The following is a description of a gene set: species: Homo sapiens Genes down-regulated in poorly differentiated thyroid carcinoma (PDTC) compared to normal thyroid tissue. Information on gene alterations associated to poorly differentiated (PDTC) and anaplastic thyroid carcinomas (ATC) is scarce. Using human cancer cell lines as a tool for gene discovery, we performed a cytogenetic and oligo-array analysis in five new cell lines derived from two PDTC and three ATC. In PDTC we evidenced, as important, the involvement of the MAPK/ERK kinase pathway, and downregulation of a group of suppressor genes that include E-cadherin. In ATC, downregulation of a specific group of oncosuppressor genes was also observed. Our ATC cell lines presented chromosomal markers of gene amplification, and we were able to identify for the first time the nature of the involved amplicon target genes. We found that the main molecular differences between the two cell line types were related to signal transduction pathways, cell adhesion and motility process. TaqMan experiments performed for five amplicon target genes and for two genes, which allowed a clear distinction between ATC and PDTC: CDH13 and PLAU corroborated array results, not only in the cell lines, but also in an additional set of primary 14 PDTC and three ATC. We suggest that our findings may represent new tools for the development of more effective therapies to the hitherto untreatable ATC. Human Gene Set: RODRIGUES_THYROID_CARCINOMA_POORLY_DIFFERENTIATED_DN from publication Rodrigues RF, Roque L, Krug T, Leite V (PMID 17406368), and this is the list of marker genes: ENOSF1, C9orf85, PPP1R21, SCARB2, HIVEP2 (NCBI Gene Id 3097, HIVEP zinc finger 2), DICER1, LRRC37A2, KSR1, CTSB, TBC1D32, JUN (NCBI Gene Id 3725), TNFRSF11A, HLA-DPA1, MAP3K1, C3orf52, TMTC1, VPS51, CACNA2D1, NFKBIA, GTF2H3, HES1, TTC7A, CTNND1, SLC41A1, RNF170, PLEKHH1, CD24P2, HBB, CD74, ACAA1, PRTG, UNC45A, RAB40B, RNASET2, TULP4 (TUB like protein 4), SLC25A3, SSBP2, PNISR, NEAT1, MGC16275, RILPL2, ABLIM1 (NCBI Gene Id 3983), CSNK2A1, COL3A1, CACHD1, BOC, ALDH3A2, SNTB1, MTMR10, IKZF2, SOBP, CDK13, FMNL3, MACROD1, APBB2, ZNF160, ACACB, METAP2, ANAPC5, CTSK, NOPCHAP1, ATF7IP, RFX1, MAN2C1, CD44, H3-3B, HLA-DRB1, NFIC, PRR4, ZNF573, CES2, FBXO25, NAMPT, MLXIP, HSD17B7, RPS6KA5, PLIN3, MBNL1, TCF4, PTPRB, RRBP1, TUSC2, SNAP23, C2orf68, PPP3CB, LNX1, XPO7, ACTA2, FZD5, SPRED1, CRIPT, ALDH5A1, YPEL1, CXorf38, ERAP1, DEDD2, MALAT1, WDR7, EPB41L5, RASSF4, SNRK, CIRBP, ATP1A1, HHEX, MRPL30, SBSPON, ELL2, TMED4 (transmembrane p24 trafficking protein 4), RGS5, MT1G, TSPAN31, GNAS, ZNF264, FBXO34, OFD1, TOX4, SNX1, SLC41A3, ERO1B, EPM2AIP1, ZBTB4, AKT3, PCBP2, LIMD1, MCCC2, CDON, MAP3K5, GRAMD2B, AGTR1, TSPAN6, AMY1A, GATM, ARID2, SLC4A4, RBPMS, NT5C3B, ITGAV, MAGI2, AKR1C1, WWOX, UVSSA, ZBTB18, NEDD9, UST, STMN3, RFFL, MAN2B2, ZNF75A, HAUS2, CLIP1, LATS1, DNASE1L1, FAM111A-DT, PROM2, SUGT1P3, TPST2, PRICKLE2, BBIP1, ECHDC2, RBL2, DMD, KLHDC1, ZMYM5, ACOX1, ELF2, SH3YL1, MYLK, MED13L, CCDC152, ARL4D, LTBP3, H1-10, KBTBD7, CXCL12, CITED2, DYNLL2, ATXN1-AS1, SLC45A4 (solute carrier family 45 member 4), SLC12A8, PPP6R2, CAPN3, ZNF587B, UBL3, PAX8, TNS3, ATP8A1, RNF213, SECISBP2L, PTEN, GSN, HTATIP2, TMEM106B, LINC01140, CLU, COL4A1, MFSD14CP, SUGT1, TNRC6B, ZBTB3, CYBRD1, THNSL2, NOP53, TOB1, GPRASP2, PLPP1, PPP1CB, NEK4 (NCBI Gene Id 8380), KRT7, POR, CRYL1, TCTA, FBXO30, NCOR1, FLNB, SOCS2, MSANTD2, INO80D, RBMS3, GPBP1L1, PPARD (peroxisome proliferator activated receptor delta), PATJ, PEBP1, TEF, RILPL1, ANXA4, ZNF362, CDC42EP4, EFNA1, RHOQ, KANSL1-AS1, GALNT10, SELENOK, RETREG3, ARID1B, NET1, KLHL41, LIFR, SAMD13, SLC66A3, ZNF8, EPHA4 (EPH receptor A4), PEX7, ESAM-AS1, ANGPTL1, ARHGEF3, PIK3IP1, HSD17B8, CCDC92, ADD3, ITGB8, ADD1, CCDC18-AS1, PKP4, PTGER4, USP34 (NCBI Gene Id 9736), ANKS1A, COL4A2, RNF144B, NDUFB4, CYB5D1, KDM4B, LINC00667, OCLN, MOB3B, SNHG5, RERE, MED31, CHD9, IRS1, COL4A3, MAGI1, MYLIP, BTD, RAPGEF5, FZD3, EHD4, GCNT1, POLI, HIPK3, IRAG1, NUTM2A-AS1, CBX7, ZNF599, AAK1, VWA5A, SEC62, FOLR1, LRIG3, LIMCH1, IVD, FAM199X, FTX, VGLL4, STN1, HOOK3, INPP5A, PAPOLG (NCBI Gene Id 64895), ARL5A, SETD2, MKRN1, TM2D1, PDLIM5, PRKAG2, TAGLN, NUDT16L2P, TXNL1, LBH, CABIN1, TOM1L2, PIP4K2B, DNAJB2, SLAIN2, TMF1, LIG3, NSD1, RASA4, GPD1L, SPP1, BBS1, TMEM241, WDR33, TMEM150C, APOLD1, PPP1R13B, KIAA1217, LSM14A, PI4KB, FBLN1, SORD, CSRNP1, CHASERR, SHANK2, CAPN1, MED28, REV1, MTMR3, KCTD10, MED6, LINS1, TCAF1, MXI1 (NCBI Gene Id 4601), TUBGCP2, GLCCI1 (NCBI Gene Id 113263), CHKB, GNAL, ZNF587, ANO10, SPATA13, LSR, PARD6G, MDM4, CST3 (cystatin C), NDUFS8, CLN5, PHC3, TBC1D4, KIAA1671, FBXO7, GID8, CCN2, HSD17B6, TRIM38, LGMN, MAP3K20, DCLRE1C, SP1, KDM3B, ST7-AS1, KMT5B, ORMDL3, SCD5, GPRASP1, SELENOP, SUSD6, AGO3, ALDH2, PTPRG, LINC03072, KAT2B, ZNF652, EDNRB (endothelin receptor type B), FYCO1, FKBP5, L3MBTL1, DHRS1, RECK, GPRC5A, TMEM164, LEPR, ZNF506, MED29 (mediator complex subunit 29, NCBI Gene Id 55588), DTNA, FAM161B, COL8A1, ABCA8, SLC40A1, ARL17A, UBR5-DT, EPB41L4B, ZNF875, AKAP9, SLPI, PID1, GON4L, MRPS30, TBC1D1 (NCBI Gene Id 401125), ERMP1, TBC1D24, NDUFA5, RBM5, MLLT6, PDK2, TGFBR2, WHAMMP4, SNX5, PCYOX1, AKAP1, CLDN10, TSPAN12 (NCBI Gene Id 23554), GSPT1, SERPINA1, FOXO1, RNF146, KBTBD4, NKAPD1, ALAD, SGPP2, BCL2, DCTD (dCMP deaminase), PROX1, MRPL19, HIPK2, SNRPA1, GGNBP2, ZNRF1, TMEM171, CPE, ZBED3, ECM2, ANAPC16, KLHL24, MED23, ERBB3, HLA-DPB1, UFL1, MMRN2, NFIA, PCMTD1, SIDT2, BAG5, TPCN1, GSTK1, DENND6A, KRT8, RABL2B, PPP2R2A, PNRC1, ZNF431, RMDN1, TBL1XR1, MXRA7, TAPBPL, SLC1A1, SRSF11, KLF6, SYNJ2, BEX4, KCTD12, RAP1GAP, HOMER2, ALMS1, TPMT, CRTC3, ZBTB2, ZFYVE21, ZNF682 (zinc finger protein 682), NUDT16, TXNIP, EPM2A, SNORD60, CPQ, SYNE2, STIM1, RPL15, TALAM1, ZFP36L2, BBX, SLCO3A1, DHRS3, B3GALNT1 (beta-1,3-N-acetylgalactosaminyltransferase 1 (Globoside blood group)), LTBP2, PDCD2, NINJ2-AS1, TRAK1, TSC22D1, ITPR1-DT, LRRFIP1, PLLP, SLC38A10, GXYLT2, SRRM2, CLMN, PNISR-AS1, TSHZ1, PTPN4, SRI, N4BP2L2, PITPNA, STX12, GOLGB1, RBM8A, CD47, NANOS1 (NCBI Gene Id 340719), CHD2, SIAE, ZEB2, MT1F, ZNF319, NPIPB3, MRI1, NR1D2, PROM1, SERF2, NF1, RAB18, RPUSD3, RSPH3, FMOD, FAM76A, KANSL1, INAFM2, SPRY4-AS1, SIK3, PDE4C, FAM117A, OPN3, PPIL6, MTARC2, EPCAM, HECTD1, LIMK2, DDX17, NIPAL3, TMEM80, SPDYE1 (speedy/RINGO cell cycle regulator family member E1), CYLD, FBXO3, CYB561, LIPG, ZSCAN18, PGF, SMAD4, PHACTR2, ZNF493, SGK1, CASP6, MYO9A, C8orf88, ITPRID2, TIAM2, LRP8, GOLGA8N, ZMYM2, PURA, FBXO9, ZNF512B, GABPB1-IT1, RALGAPA2, LRCH3, CCND2, INTS6-AS1, HCLS1, CSRP1, PSD4, IL11RA, MROH1 (maestro heat like repeat family member 1), PIGV (phosphatidylinositol glycan anchor biosynthesis class V), BCAM, PRAG1, ZNF487, AKAP10, ZNF207, TMT1A, CPEB3, DCAF8, RSF1, LAMA4, MIA2, SMARCE1, GADD45B, SMAD9, GPX3, FMO5, CD59, GPATCH2L, RNF135, FAM66A, ITPR1, MXRA5, LLGL2, TCTN1, CENPL, PLPP3, MATN2 (matrilin 2), MANSC1, SASH1, PLAT, SLC25A29, SELENBP1, DEXI, GLIPR2, CBR4, TEFM, PAGR1, TARS3, BHLHE41, YIPF4, WASF3, CAPS2, VAPB, RNF38, C4A, PARP8, WDR72, CDS1, USP54, FBXL17, VCF2, ZNF331, SLC29A1, NELFA, UBE2D3, CYTH1, PTCSC1, GLUL, NEO1, ERCC6L2, HIRA, ZDHHC2, RAP1A, TNS1, ENPP5, ABI2, LONP2, TMCC3, RNF217, CFLAR, EIF4E3, PRMT2, SLC18B1, BSDC1, RNF141, KIF9, ST3GAL1, HERC1, MBP, ZNF250, ZNF492, AHCYL2, CROT, SLC26A7, CCL28, TNFAIP8, CD24, SORL1, JUND, ZNF611, TEX2, PDF, ST6GAL2, DENND2B, GPR160, FOXP1, KATNBL1, ENSG00000287769, ITGA1, SESN1, MRTFB, AKT2, UBTF, CROCCP2, ZBTB46, CUL3, SPTBN1, ARSD, WDPCP, PER3, ENPP2, HEBP1, CCDC80, UBN2, FBXO21, ERBB2, GABPB1-AS1, LRIG1, SEC63, MSI2, TRIM13, SMIM10L2A, ABHD14A, FHDC1, CASC3 (CASC3 exon junction complex subunit), THBS1, MAN1B1-DT, AFF4, ZBED5-AS1, CAT, TGFBR3, TRAPPC6A, FNBP1, H19, SUDS3, ATXN3, SLC39A14, TTC5, XRCC2, GJA1, FAM13A, NUDT3 (nudix hydrolase 3), PLG, AP4S1, PGAP3, ANKRD28, RCAN3, KANK1, LYRM9, ACAD8 (NCBI Gene Id 27034), ARHGAP5, RSBN1, WFDC2, RBM26-AS1, ZNF518A, PFKFB2, F11R, TSPAN5, NR2F2, PINK1, MAPK13, PHF11, FGD4, TMBIM1, CD302, MARVELD2, KLHDC8B, MAF (MAF bZIP transcription factor), SORBS2, MYL4, PIAS1, PODXL, TAB2 (NCBI Gene Id 23118), SUPT20H (SPT20 homolog, SAGA complex component), DPYSL3, VPS13C, ENY2, PTCD1, ATXN1, AFDN, ARHGAP1, MRPS25, ABCG1, HSCB, STRBP, ABAT, ARFGAP2, ZFHX3, GUSBP14, TMEM178A, SMPDL3A, NKTR, ASAP3, CDKL5, SDC2, TMEM65, PELI1, SNED1, EPB41, PAPOLA, CCDC28A, CDK10, POGZ, EMP1, SLC9A7, TOB2, MGRN1, FBN1, PAK1, BICRAL, GRHL2, PDGFD, TNFAIP3, DDR1, WDR11, PDCD4, SH3RF1, QNG1, HDAC11, DNAJC5, ARL17B, ZBTB20, RELL1, WWC1, MIR3685, METTL9, ANKRD10 (ankyrin repeat domain 10)